The following is a description of a gene set: Any process that modulates the frequency, rate or extent of an endoplasmic reticulum stress-induced intrinsic apoptotic signaling pathway. species: Mus musculus Mouse Gene Set: GOBP_REGULATION_OF_ENDOPLASMIC_RETICULUM_STRESS_INDUCED_INTRINSIC_APOPTOTIC_SIGNALING_PATHWAY, and this is the list of marker genes: Bok, Hyou1, Fcgr2b, Ikbkg, Nck2, Tmbim6, Prkn (NCBI Gene Id 50873), Bcl2l1, Park7, Lrrk2, Erp29, Serinc3, Rnf183, Sirt1, Grina, Wfs1, Syvn1, Herpud1, Spop, Ptpn2, Creb3, App, Creb3l1, Pdx1, Ptpn1, Txndc12 (thioredoxin domain containing 12 (endoplasmic reticulum)), Selenos, Nck1, Eif2ak3, Xbp1, Opa1